Given this list of marker genes LCP1, FZR1, CDC42SE2, TNFAIP8, MIR124-1HG, CLEC6A, C1orf74, SIN3B, PCTP, GNPDA1, CYP4F22, HEBP1, ERP29, UBASH3B, FAM163A, TRIM8, IL1RAPL2, SLC22A16, RB1, TRIM14, TNFSF13B, ZMAT4, IFI44L, SERP1, KCNE3, SEMA5B, XYLT2, ZIM2, ATP6V1E2, ROGDI, PACSIN1, TMEM273, RPH3A (rabphilin 3A), NPL, IKZF1, TASL, MPEG1, MTM1, TTC7A, CMTM3, IPCEF1, SNAP23, SH3YL1, FXYD4, OTULIN, LY9, MORN3, CLHC1, NLN, NKIRAS1, GSAP (gamma-secretase activating protein), SLC39A2, SHTN1, MFSD12, ASCL1, KLRC2, SPMAP1, SFTPB (NCBI Gene Id 6439), SYNGR1, TASP1, HPS3, ARHGDIB, CTSC, BASP1, PHF21B, SHPK, NAT9, CCDC180, PALB2, GMFG, CENPO, PHOSPHO1, ACP5, CFAP157, ARHGEF19, NAT8L, VIPAS39, CD52, BOLA2, GPR137B, PYM1, NKG7, SKAP1, ACAD10, MYO9A, CFAP161, SIMC1, ANKS3, ST18, PDP1, PTPRE, SOHLH2, SEMA4D, SNRNP35, CAPN13, RBP2, NAT1, DYNLT2B, PTPRJ, LYN, PKIB, TMEM150B, DNAJC16, ALAS1, GFM2, MEIKIN, ATPAF2, AP2B1, TEX44, BATF2, PLA2G4F, CXCL16, FAT2, YIPF6, DDX25, LPCAT4, SGMS1, APOBEC1, NSUN3, PID1, AMER2, EVI2B, PHACTR3, KLHL4, GIN1, CDCA5, MRPS18C, TNFRSF1B, MXD3, NPAS4, FOXD2, CD300C, CCL24, EYA3, HEY1, DNA2, BTBD19, TNFRSF8, FBH1, RNF180, CSTF2, CFI, IRF8, CBLC, MXRA7, C4orf19, FASTKD3, KCTD12, CA5A, SPACA7, FIBCD1, PTPRC, KRT28, AQP3 (aquaporin 3 (Gill blood group)), SMIM12, TMEM209, ECEL1, CUEDC1, RYR1, TRIP12, FCGR2B, SLC5A4, CMPK1, MDK, MRGPRG, CCDC82 (coiled-coil domain containing 82), DNAI3, CHODL, CES3, NFE2, DDX27, CEP164, ANKRD2, CLEC5A, COTL1, LACC1, CCDC88B, SLC22A12, EPN3, TEKT1, SH3BGRL2, OTULINL, C14orf93, EPCAM, IGSF6, DENND1C, PRSS36, TMEM167A, ABCC6, PRPF40A, INA, TLR6, MED11, GNA15, GNPTAB, NXNL2, PGK2, BCO1, RPL41, TRIM65, here is a description of the gene set: Human Gene Set: GSE32533_MIR17_KO_VS_MIR17_OVEREXPRESS_ACT_CD4_TCELL_DN Genes down-regulated in activated CD4 T cells with MIR17 perturbation: knockout versus over-expression. studied in species Homo sapiens miR-17 from the miR-17-92 cluster regulate activation-induced cell death in T cells and modulate inducible regulatory T cell differentiation. We used microarrays to detail the global program of gene expression modulated by miR-17 and aim to identify the potential targets of miR-17. from publication Jiang S, Li C, Olive V, Lykken E, Feng F, Sevilla J, Wan Y, He L, Li QJ (PMID 21972292)